The following is a description of a gene set: Genes up-regulated in comparison of dendritic cells (DC) stimulated with CpG DNA (TLR9 agonist) at 0.5 h versus those stimulated with CpG DNA (TLR9 agonist) at 8 h. mouse primary BMDCs were stimulated with tlr ligands and gene expression changes were profiled on Affymetrix arrays from publication Amit I, Garber M, Chevrier N, Leite AP, Donner Y, Eisenhaure T, Guttman M, Grenier JK, Li W, Zuk O, Schubert LA, Birditt B, Shay T, Goren A, Zhang X, Smith Z, Deering R, McDonald RC, Cabili M, Bernstein BE, Rinn JL, Meissner A, Root DE, Hacohen N, Regev A (PMID 19729616) Human Gene Set: GSE17721_0.5H_VS_8H_CPG_BMDC_UP species: Homo sapiens, and this is the list of marker genes: SH3BP1, ALAD, PELO, TGFBR2, POLR2F, MTFR1L, SNX3, OCEL1 (NCBI Gene Id 79629), TMED2, VDR, GLUL, ADAM15, DAGLB, TALDO1 (transaldolase 1), GPSM3, ADSS1, QRSL1, APOBR, ANAPC5, GCNT1, ZFYVE19, METAP1D, HAUS4, STT3B, ADIPOR2, MRPL47, HPF1, CUEDC2, SUCLG1, MYO18A, SORT1, ZFHX3, ZMIZ2, CORO2A (NCBI Gene Id 7464), PLCB2, SNRPA, S100A6, PHYH, TMEM51, PDCD6, PNPO, ZNF706, RPL37A (NCBI Gene Id 6168), MRPL16, ASAH1, ICA1, TSPAN32, ATP6V0D1, NXN, RNF7, ME2, PFDN5, SHKBP1, HSP90AB1, THAP12, HSD17B4, CORO1A, COASY, REEP5, TPCN2, VOPP1, CS, RETREG1, ITGA6, GMPR, CLUH, TIMM9, SDHB, AP2S1, OSGEP, F2RL2, IFNGR1, DDX18, GMPPA (NCBI Gene Id 29926), NUDT7, CHCHD3, GNAI2, OTULINL, CD300C, LDHA, FOXO3, UQCRQ, SRPK2, RGS2, TKT, COLGALT1, ABCD1, CDK5RAP3, GPATCH4, PRR15, EXOSC5, RPA1, ITCH, DHCR24, SENP3, BORCS5, GALC (galactosylceramidase), TMEM205, HACD4, SLC37A4, MSRB1, TOP1MT, HAUS8, ANPEP, IFT140, DTYMK, PHKG2, C1QBP (NCBI Gene Id 708), SIDT2, TPRA1, RARS2, ADD1, ANKRD46, MYO9B, RGL2, TEP1, FN1, SLC25A35, TGFBI, NUTF2, FUCA1, LSS, CD99L2, MRTO4, ALDH9A1, RACK1, CERS5, PPARGC1B, SIVA1, MRPL4, BSCL2, CASP9, MAST3, ABHD17A, NDRG4, MYL12B, HMBS, RNF26, LETM1, CHCHD10 (coiled-coil-helix-coiled-coil-helix domain containing 10), BUD23, CHERP, SPEG, NSDHL, PPP1R14B, ELAC2, CHST12, FAM120A, SLC25A15, ATG3, GMNN, ZNF703, HMGA1, NOP2, MAP2K4, NUP85, PSMB1, AIF1, GPR146, MTHFD1, TEF, CEACAM21, TTYH2, MCEE, ADCY9, GOT2, CSRP2, PTPRS, SLC25A3, PLA2G15, SLC35C2, ODC1, SLC16A3, PSMG2, MAP3K14, CYB5R1, ATRAID, COPRS, ACAT2, ADGRE5 (NCBI Gene Id 976), UCK2, TEX15, FBLIM1, LZTR1, RHPN2, SLC27A3, NDUFS3, HEBP1, PER1, SS18, ETHE1, KAZALD1, ULK1, PABPC1, PRKCB, MRPS35, CNBP, WBP11, SSBP2, SMYD2